The following is a description of a gene set: Genes down-regulated in comparison of dendritic cells (DC) stimulated with LPS (TLR4 agonist) at 0.5 h versus DC cells stimulated with Gardiquimod (TLR7 agonist) at 0.5 h. studied in species Homo sapiens Human Gene Set: GSE17721_LPS_VS_GARDIQUIMOD_0.5H_BMDC_DN mouse primary BMDCs were stimulated with tlr ligands and gene expression changes were profiled on Affymetrix arrays from publication Amit I, Garber M, Chevrier N, Leite AP, Donner Y, Eisenhaure T, Guttman M, Grenier JK, Li W, Zuk O, Schubert LA, Birditt B, Shay T, Goren A, Zhang X, Smith Z, Deering R, McDonald RC, Cabili M, Bernstein BE, Rinn JL, Meissner A, Root DE, Hacohen N, Regev A (PMID 19729616), and this is the list of marker genes: SLF2, TRIM41, RAP1A, PGAP4, TFAP2C, HHATL, ATP9B, BCL2L13, BSDC1, LIMK2, PRMT1, DCLK1, ZNF280C, RBX1, SLC22A23, ASCC1, SDCBP2, CCNA1, KAT7, RPAP3, KIF5A, DHX38, MSLN, KLK4, ZNF318, TMUB1, MTA1, ATP2A1, CRX, MIGA2, RPS7, PIGT, ZNF474, BPGM, SF3B1, CLEC1B, ABHD3, SLFN12L, PARP12, CAV3, EPHX2, ZNHIT2, CEMIP, LCT, AGFG2, TAMALIN, ACTR2, RAB5C, CTPS1, SNX15, CCL25, SUZ12, KRT75, PSMD3, ANKS1A, RTTN, ALG2, RAB8B, SH3BP5L, KCMF1, MDFIC, OTUD7B, CPQ (carboxypeptidase Q), SRPK1, SNX17, KIF20A, RABEPK, FIGN, G3BP1, GINM1, EYA2, HAAO, SYN2, CCDC6, SLC22A5, GUCD1, SP110, SLC41A2, TSPO (NCBI Gene Id 706), PPM1A, EHHADH, NR1H3, TSTD2, SLC18A1, PLAC8, NCOA3, FBLN7, CDKN2C, FAM117B, KCNA6, MS4A6A, LYPLA2, CPEB4, TIMELESS, HSD3B2, CPPED1, NUDT13, RTKN, APLF, ATAD2B, TRIM8, C1QL1 (NCBI Gene Id 10882), IFIT1B, MEA1, SLC12A2, ELF4, TMEM98, SCRG1, DHCR24, NUDT3, SUMO3, HNRNPM, MYCBP2, SLC38A3, GOLT1B, STARD5, FXR1, RNF44, PLA2G15, GJB4, AP1B1, GJA4, IFT22, NEK7, LARP4B, FZD1, AKR1B10, S100A5, PSAPL1, MARCKSL1, ACTR10 (actin related protein 10), CHD7, NUDT11, WBP2, AAMP, ELP2, NPC2, SAAL1, MRPL20, LAMTOR5, CEP112, SELPLG, EFHD2, FAM76A, RAB4A, CHIC2, SMC3, TTC16, OGFOD2, B3GNTL1, WNT5B, PAQR7 (NCBI Gene Id 255358), GOLGA4, IFIT2, NBEA, MIDN, TMEM263, ELP1, STK11, DAXX, MYMK, USP7, CRY2, CAMTA2, EDEM1, RPL6, PLA2G2D, DENND6A, EMID1, DYNC1I1, DNAJC2, PRDX1, C19orf25, MKRN1, IL7, NHERF1, LCLAT1, BMP5, XBP1, CCK, ADORA2A (adenosine A2a receptor), GASK1B, SLC27A1, DMBT1, PHOSPHO2, MSN, IQGAP1, KCNK13, FIS1, TBRG4, HOXC4, PFN2, SELENOW, NFATC2IP, RPS26, ILF3, ANKH, KRT16, PTP4A2, CHMP4B